The following is a description of a gene set: A protein complex that is required for sister chromatid cohesion in eukaryotes. The cohesin complex forms a molecular ring complex, and is composed of structural maintenance of chromosomes (SMC) and kleisin proteins. For example, in yeast, the complex is composed of the SMC proteins Smc1p and Smc3p, and the kleisin protein Scc1p. In vertebrates, the complex is composed of the SMC1 (SMC1A or SMC1B) and SMC3 heterodimer attached via their hinge domains to a kleisin (RAD21, REC8 or RAD21L) which links them, and one STAG protein (STAG1, STAG2 or STAG3). Mouse Gene Set: GOCC_COHESIN_COMPLEX species: Mus musculus, and this is the list of marker genes: Sgo2a, Rad21l, Stag1, Smc3, Smc1a, Stag3, Smc1b, Stag2, Ddx11, Rad21, Rec8